The following is a description of a gene set: Binds to and modulates the activity of a potassium channel. Human Gene Set: GOMF_POTASSIUM_CHANNEL_REGULATOR_ACTIVITY studied in species Homo sapiens, and this is the list of marker genes: CAV3, WWP2, YWHAE, KCNG2, KCNMB1, SGK2, KCNS3, KCNG4, AMIGO1 (adhesion molecule with Ig like domain 1), KCNIP2, SLC5A3, C8orf44-SGK3, KCNS2, LRRC55, NEDD4, KCNIP1, DLG1, KCNE1, KCNS1, KCNMB3, SGK3, KCNV2, KCNAB3, DPP10, KCNB1, DRD2, ENSA, KCNMB2, KCNAB1, OXSR1, KCNMB4, CHP1, KCNK2, SUMO1, KCNE3, KCNE5, FHL1, LRRC26, DRD4, CAV1, KCNV1, NEDD4L, ARPP19, SGK1, ABCC9, ANK2, KCNF1, ADRB2, DPP6, STK39 (NCBI Gene Id 27347), FLNA, KCNG1, KCNE4, KCNG3, KCNE2, KCNB2, AKAP9, KCNIP4, LRRC38, KCNIP3, KCNAB2, LRRC52, RASA1, AKT1